Given this list of marker genes Agap3, P2rx6, Pdpk1, Rnf20, Dgkd, Tmtc2, Naa11, Fbxo42, Pdk1, Fam220a, Hcn3, Srprb, Map3k1, Smad2, Ero1a, Map3k9, Pogk, Eif5, Ssh2, Srl, Trmt2a, Mief1, Mrpl9 (NCBI Gene Id 99489), Rasgef1b, Iqsec1, Pradc1, Sertad2, Bex3, Gm5878, Neo1, Plxdc2, Emc7, Crisp2, Ctbp1, Zfand3, Cdc37l1, Adgrg7, Calm1, Mfsd4a, Gm14461, Clec14a, Prss42, Mfsd1, Serpinb9e, Usp49, Sdhaf4 (NCBI Gene Id 98449), Gldc, Bicral, Gpr165, Lgalsl, Arhgap20 (Rho GTPase activating protein 20), Hao1, Uap1, Tnrc6a, Zbtb21, Crem, Arsk, Lrrc14, Ptpn5, Rcor1, Trim66, Ddx21, Usp22, Pde7a, Asz1, Serpinb9f, Tubb2b, Lratd1, Kras, A930018P22Rik, Gdpd4, 2310039H08Rik, Ctso, Itpr1, Ankib1, Tango2, Arid2, Eaf1, Slc25a36, Ttc14, Fhl1, Zfhx3, Sult1c1, Fsd1l, here is a description of the gene set: species: Mus musculus Mouse Gene Set: MIR_1197_3P from publication Chen Y, Wang X (PMID 31504780) Genes predicted to be targets of miRBase v22 microRNA mmu_miR_1197_3p in miRDB v6.0 with MirTarget v4 prediction scores > 80 (high confidence targets).